Given this list of marker genes Bcl3, Ddx39a, H2-Eb1, Armcx6, Rasgrp3, Iqgap1, Arpc5, Cd8a, Acadl, Mt1, Alcam, Hcls1, Ifi204, Pim1, Nrros, Igkc, Bbx, Isg20, Actg1, Atp1b3, Ifi44, Adprh, Cdh22, Treml2, Aldh1b1, Nlrc5, Cd86, Ctsh, Psme2, Ldlr, Wfdc21, Rpia (ribose 5-phosphate isomerase A), H2-Ab1, Rbms1 (RNA binding motif, single stranded interacting protein 1), Sp100, Dtx3l, Ezh2, Ambra1, H2-D1, Hspa8, Ly6c2, Atp5mc1, Hsp90aa1 (NCBI Gene Id 15524), Ankrd54, Ssr1, Oas3, Ppa1, Sp110, Mx1, Cyba, H2-Aa, Cd69, Psmd1, Edf1, Cfl1, Gabarap, Ly6e, Eif2ak2, Ly6a, St13 (suppression of tumorigenicity 13), Plxnc1, Rbm3, Hsp90ab1, Lgals3, Psmb2, Tpm3, Ube2l6 (NCBI Gene Id 67250), Nmi, Gtpbp4, Sc5d, Ifi207, Ifi35, Hivep3 (NCBI Gene Id 73003), Trim30b, Cd52, Ifit2, Sdhaf1, Cd48, Nampt, H2-Q7, Tap2, Anp32a, Cyp51, Hmgcs1, Cd72, Usp18, Edem1, Sct (NCBI Gene Id 20287), Tmem168, Ubr4, Slc43a3, Mndal, Csf2rb2 (NCBI Gene Id 12984), Cd74, Idi1, Gapdh, Xaf1, Sec61g, Napsa, Litaf, M6pr, Oasl2, Ly6d, H2aj, Trim30d, Iigp1, Glipr1, Hspa5 (heat shock protein 5), H2-DMa, Batf, Lgals9, Ints3 (NCBI Gene Id 97059), Slc15a3, Basp1, Phf11d, Ass1, Il2rg, Calm1, Msn, Slc38a2, Phf11b, Gtf3c6, Adar, Phf11a, Rtn4, Tuba1b (NCBI Gene Id 22143), Stat2, Tmem176b, St8sia6, Tubb4b, Il4i1, Hmgcr, Gnb1, Rnf114, Srsf2, Azin1 (antizyme inhibitor 1), Fcer1g, Gng12, Sdc3, Pecam1, Zbp1 (Z-DNA binding protein 1), H2-K1, Grn, Sqle, Sub1, Rftn1, Fam110a, Eif5a, Tapbp, Ctsz, Isoc1, Itgax, Rap1a, Ifi211 (interferon activated gene 211), Arpc2, Rnf213, Mvp, Sar1a, Gbp2, Shisa5, Grb2, Ccnd2, Cd82, Ifi203, Tmem176a, Sgcb (NCBI Gene Id 24051), Lgals1, Lad1, Cotl1, Tmbim6, Plxnd1, Gbp6, Thyn1, Tent5c, Arpc4, Mpeg1, Pdia3, Apod, Ftl1, Myl6, Lrp8, Trafd1, Cnppd1, Gpr65, H2-T23, Bcl2a1b, H3f3a (NCBI Gene Id 15078), Lyst, Traf1, Chmp4b, Cnn2, Mphosph6, Isg15, Cd36, Tmsb10, Erh, Lcp1, Ncl, Niban3, Cyb5b, Lynx1, Psma3, Tnni1, Myl12a, Cfp, Parp14, Stat1, Ifitm3 (interferon induced transmembrane protein 3), Tap1, Socs3, Gpx4, Mif4gd, Asb13, Fdps, Pkib, Bcl2a1d (B cell leukemia/lymphoma 2 related protein A1d), Msmo1, Irf7, Parp11, Swap70, Chchd2, B2m, Etv6, Ifih1, Cd44, Tpm4, Irgm1, Ifi47, Aida, Senp6, Kdr, Hck, Trim12c, Slfn5, Lgals3bp, Ece1, Gsr, Fbxw17, Ctsc, Uap1l1, Klrk1, Ebi3 (Epstein-Barr virus induced gene 3), Lgmn, Dhx58, Casp8, Cd40, Ifi209, Exosc3, Ifi27l2a, Calr, Trim30a, Itgb1, Pgap2, Ccr7, Srgn, Mfsd12, Nab1, Ifitm2, Pfn1, Prdx1, here is a description of the gene set: Cytokines mediate cell-cell communication in the immune system and represent important therapeutic targets. A myriad of studies have highlighted their central role in immune function, yet we lack a global view of the cellular responses of each immune cell type to each cytokine. To address this gap, the authors created the Immune Dictionary, a compendium of single-cell transcriptomic profiles of more than 17 immune cell types in response to each of 86 cytokines (>1,400 cytokine-cell type combinations) in mouse lymph nodes in vivo. A cytokine-centric view of the dictionary revealed that most cytokines induce highly cell-type-specific responses. For example, the inflammatory cytokine interleukin-1β induces distinct gene programmes in almost every cell type. A cell-type-centric view of the dictionary identified more than 66 cytokine-driven cellular polarization states across immune cell types, including previously uncharacterized states such as an interleukin-18-induced polyfunctional natural killer cell state. species: Mus musculus Mouse Gene Set: CUI_PDC_IL36A_RESPONSE_UP from publication Cui A, Huang T, Li S, Ma A, Pérez JL, Sander C, Keskin DB, Wu CJ, Fraenkel E, Hacohen N (PMID 38057668) Genes positively differentially expressed in cell type: pDC (plasmacytoid dendritic cell) upon treatment with cytokine: IL-36α in mouse lymph nodes in vivo.